Given this list of marker genes TOB1, MNT, BTG2, SKAP2, ABI1, ATR, here is a description of the gene set: Human Gene Set: DONATO_CELL_CYCLE_TRETINOIN from publication Donato LJ, Suh JH, Noy N (PMID 17234770) The anticarcinogenic activities of retinoic acid (RA) are believed to be mediated by the nuclear RA receptor (RAR) and by the RA-binding protein cellular RA-binding protein-II (CRABP-II). In MCF-7 mammary carcinoma cells, growth inhibition by RA entails an early cell cycle arrest followed by induction of apoptosis. Here, we aimed to obtain insights into the initial cell cycle response. We show that a 3- to 5-h RA pulse is sufficient for inducing a robust growth arrest 2 to 4 days later, demonstrating inhibition of the G1-S transition by RA is triggered by immediate-early RAR targets and does not require the continuous presence of the hormone throughout the arrest program. Expression array analyses revealed that RA induces the expression of several genes involved in cell cycle regulation, including the p53-controlled antiproliferative gene B-cell translocation gene, member 2 (Btg2) and the BTG family member Tob1. We show that induction of Btg2 by RA does not require de novo protein synthesis and is augmented by overexpression of CRABP-II. Additionally, we identify a RA response element in the Btg2 promoter and show that the element binds retinoid X receptor/RAR heterodimers in vitro, is occupied by the heterodimers in cells, and can drive RA-induced activation of a reporter gene. Hence, Btg2 is a novel direct target for RA signaling. In concert with the reports that Btg2 inhibits cell cycle progression by down-regulating cyclin D1, induction of Btg2 by RA was accompanied by a marked decrease in cyclin D1 expression. The observations thus show that the antiproliferative activity of RA in MCF-7 cells is mediated, at least in part, by Btg2. species: Homo sapiens Genes involved in cell cycle regulation which were up-regulated in MCF-7 cells (breast cancer) by tretinoin (retinoic acid).